Given this list of marker genes DDRGK1, ERN1, BAX, DAB2IP, XBP1, DNAJC10, FICD, PARP16 (NCBI Gene Id 54956), UFL1, HSPA5, BBC3, ERN2, COPS5, VAPB, PTPN1, TMBIM6, TMEM33, BCL2L11, DNAJB9, BFAR, AGR2, BAK1, here is a description of the gene set: Human Gene Set: GOBP_IRE1_MEDIATED_UNFOLDED_PROTEIN_RESPONSE The series of molecular signals mediated by the endoplasmic reticulum stress sensor IRE1 (Inositol-requiring transmembrane kinase/endonuclease). Begins with activation of IRE1 in response to endoplasmic reticulum (ER) stress, and ends with regulation of a downstream cellular process, e.g. transcription. One target of activated IRE1 is the transcription factor HAC1 in yeast, or XBP1 in mammals; IRE1 cleaves an intron of a mRNA coding for HAC1/XBP1 to generate an activated HAC1/XBP1 transcription factor, which controls the up regulation of UPR-related genes. At least in mammals, IRE1 can also signal through additional intracellular pathways including JNK and NF-kappaB. species: Homo sapiens